The following is a description of a gene set: Human Gene Set: GOBP_POSITIVE_REGULATION_OF_PEPTIDYL_SERINE_PHOSPHORYLATION studied in species Homo sapiens Any process that activates or increases the frequency, rate or extent of the phosphorylation of peptidyl-serine., and this is the list of marker genes: EGFR, BRAF, PFN2, RAF1, LIF (NCBI Gene Id 3976), STOX1, IL6, CREBL2, MAD2L2, TRIM6, PDCD10, AKT1, OSM, SPRY2, STK4, CNOT9, ERCC6, TENM1, IRGM, ARAF, IFNG, IL11